Given this list of marker genes Ptpn2, Ptprc, Cd300lf, Parp14, Cd40, here is a description of the gene set: studied in species Mus musculus Any process that modulates the frequency, rate or extent of interleukin-4-mediated signaling pathway. Mouse Gene Set: GOBP_REGULATION_OF_INTERLEUKIN_4_MEDIATED_SIGNALING_PATHWAY